The following is a description of a gene set: Mouse Gene Set: MONNIER_POSTRADIATION_TUMOR_ESCAPE_UP from publication Monnier Y, Farmer P, Bieler G, Imaizumi N, Sengstag T, Alghisi GC, Stehle JC, Ciarloni L, Andrejevic-Blant S, Moeckli R, Mirimanoff RO, Goodman SL, Delorenzi M, Rüegg C (PMID 18794119) Radiotherapy is widely used to treat human cancer. Patients locally recurring after radiotherapy, however, have increased risk of metastatic progression and poor prognosis. The clinical management of postradiation recurrences remains an unresolved issue. Tumors growing in preirradiated tissues have an increased fraction of hypoxic cells and are more metastatic, a condition known as tumor bed effect. The transcription factor hypoxia inducible factor (HIF)-1 promotes invasion and metastasis of hypoxic tumors, but its role in the tumor bed effect has not been reported. Here, we show that tumor cells derived from SCCVII and HCT116 tumors growing in a preirradiated bed, or selected in vitro through repeated cycles of severe hypoxia, retain invasive and metastatic capacities when returned to normoxia. HIF activity, although facilitating metastatic spreading of tumors growing in a preirradiated bed, is not essential. Through gene expression profiling and gain- and loss-of-function experiments, we identified the matricellular protein CYR61 and alphaVbeta5 integrin as proteins cooperating to mediate these effects. The anti-alphaV integrin monoclonal antibody 17E6 and the small molecular alphaVbeta3/alphaVbeta5 integrin inhibitor EMD121974 suppressed invasion and metastasis induced by CYR61 and attenuated metastasis of tumors growing within a preirradiated field. These results represent a conceptual advance to the understanding of the tumor bed effect and identify CYR61 and alphaVbeta5 integrin as proteins that cooperate to mediate metastasis. They also identify alphaV integrin inhibition as a potential therapeutic approach for preventing metastasis in patients at risk for postradiation recurrences. studied in species Mus musculus The postradiation tumor escape signature: genes up-regulated in tumors from irradiated stroma vs those from non-irradiated stroma., and this is the list of marker genes: Elac2, Cfap45, Urb2, Grwd1, Oasl1, Zkscan3, Slc6a8, Srek1, Atp1a1, Pmm2, Lhfpl6, Abce1, Camk2d, Ppif, Pdpn, Kat2a, Akap1, Ahrr, Rassf1, Kansl2, Sntb2, Hspa4l, Otud4, 1110038B12Rik, Rrp8, Mlec, Ccnb1ip1, Atp2b1, Ddx6, Tirap, Zfp91, Ube2l3, Tspan14, Hspa1b, Rab35, Naa15, Chd4, Vat1, Dusp9, Ankrd33b, 6030458C11Rik, Cdh5, Srm, Ccar1, G3bp2, 2610005L07Rik, Map3k7, Gng12, Ppat, Rbm25, Cdk8, Msi2, Adipor1, Il11, Slc10a3, Nqo1, Atp1b1, Oxr1, Fam167b, Elp1, Blnk, Prkar2b, Dnmt3l, Rlim, Ramp3, Rrp7a, Tex261, Grem1, Aebp1, Lypd3 (NCBI Gene Id 72434), Xpo4, Sh3pxd2a, Zfp335 (NCBI Gene Id 69801), Nmt2, Mrpl15, Ddx46, Spire2, Deptor (NCBI Gene Id 97998), Ergic1, Bnc2, Slc11a2, Neat1, Bace1, Ccnt1 (NCBI Gene Id 72830), Fkbp4, Luc7l3, Usp20, Kif21a, Itprip, Prcp, Kpnb1, Csnk1g1, Tada2b, Tfdp2, Eaf1, Zfyve27, Tsr1, Tbrg4, Scap, Slc25a10, Nrp1, Dhx33, Rbm14, Ass1, Smad1, Ptpn11, Ttpal, Pgs1, Dus3l, Dap, Wipf2, Sec22c, Zdhhc3, Tardbp, Tango6, Ago2, Hgh1, Rack1, Naa16, Mmp2, Zfp866, Crebbp, Txlna, Zc3h18, Utp4, Mtf2, Lrig1, Rad23b, Ablim1, Ubiad1, Mtr, Rrp12, Crhr1, Xpo6, Ap1ar, Mafg, Smim36, Slc39a6, Rbm27 (RNA binding motif protein 27), Mfsd10, Sgip1, Ak1, Zmpste24, Nop9, Txnrd1, Ampd2, Gm42047, Xpo5, Mmd, Slc19a1, Odc1, Rnd1, Pik3r1, Gpc1, Lrrc14, Smurf1, Prpf4, Fastkd3, Dync1li2, Ints6, Pdzrn3, Ssx2ip, 1700041M19Rik, Eif4g1, Trim2, Fam149a, Pabpn1, Gpd1l, Faap24 (Fanconi anemia core complex associated protein 24), Gls, Prr3, G6pdx, Ptgs1, Bbx, Slc48a1, Naa25, Pdap1, Pa2g4 (proliferation-associated 2G4), Slc25a32, Traf4, Ddx54, Ppm1l, Pdpr, Syncrip, Akr1b1 (aldo-keto reductase family 1 member B), Aqp5, Lrrc59, Cdk2ap1, Senp2, Mtmr9, Crebzf, Nop56, Bap1, Pigl, Kctd17, Sec23ip, Fdx1, Selenow, Rnf183, Zmynd19, Socs6, Khdc4, Asrgl1 (NCBI Gene Id 66514), Fam53c (family with sequence similarity 53, member C), Clec1a, Faim2, Pnpla6, Senp3, Fam98a, Gm17491, Pwp2, Pde12, Strap, Smyd5, Shroom4, Cenpa, Cxcl5, Ttc39c, Bop1, Abcc1, Uaca (uveal autoantigen with coiled-coil domains and ankyrin repeats), Gclm, Map2k3, Sdc1, Proser1, Clba1, Cntn2, Asph (aspartate-beta-hydroxylase), Gatad2a, Tsc22d1, Supv3l1, Tns3, Ddx51, Pabpc4, Rab5c, Mcc, Vcan, Fam83g, Nipbl (NIPBL cohesin loading factor), Slmap, 5033421B08Rik, Kcnk5, Kcnq1ot1, Trmt61a, Nnmt, Ddx3x, Ash2l, Pdcd11, Slc35a4, Scai, Espl1, Ppp1r10 (NCBI Gene Id 66450), Slc35b4, Airim, Iapp, Kcnu1, Fam32a, 2700038G22Rik, Samd4, Ccdc93, Dhx9, Il1rl1, Pcx, Trmt6, Gldc, Anxa11, Prpf3, Ipo4, Gtf3c6, Mrps15, Ankrd13a, Usp19, Rapgef6, Zmat3, Fastkd1, Nhlrc2, Eif3b, Enpp2 (NCBI Gene Id 223584), Smarcc1, Alg10b, Pgd, Sdad1, Traf2, Scin, Slc66a2, Rcc1, Taok1, Aph1a, Sltm, Hmga1, Prmt6, Rcc1l, Wdr46, Nolc1, Tspan5, Aven, Slco3a1, Letm1, Smarca4, Map4k4, Nfkbie, Bcat1, Tpm1, Marchf5, Ilrun, Yap1, Pcbp2, Ino80e, Prkca, Vps33a (NCBI Gene Id 77573), Zfp267, Rab8b, Actr1b, Mir1949, Slc7a6, Gemin5, Mettl1, Slc12a2, Mtdh, Slc22a23, Ftsj3, Fosl1, Gtf2h1, Ints13, Gspt1, Nol8, Nploc4, Cisd3, Ppm1f, Slit2, Sumo3, LTO1, Poldip2, Il18r1, Sptbn1, Aen, Dynll2, Prl2c2, Sfpq, Ncbp1, Mybbp1a, Ets1, Lonp1, Myo10, Btaf1, Xdh, Mthfd1, Slc14a1, Ccl5 (NCBI Gene Id 20304), Bms1, Pcyt1a, Zfp560, Mybl2, Marcksl1, Letmd1, Gmps, Ppp1r12b, Tnfaip2, Eif4ebp2, Thoc3, Hspa4, Rwdd4a, Hipk1, Snhg3, Eeig1, Pop1 (NCBI Gene Id 67724), Ereg, Gosr2, Rbm19, Alkbh1, Gclc, Nemf, Rsrc2, Myd88, Rhoj, Ints2, Atp2a2, Slc15a3, Gon4l, Hnrnpk, Abitram (actin binding transcription modulator), Mrgprf, Otud7b, Ncs1, Brd2, Smg5, Mcmbp, Cdk6, Srprb, Polr1a, Rapgef1, Kmt5a, Man1a, Slc25a44, Lbhd1, Mlst8, Ltbp1, Mei1, Ptdss1, Pnn, Zfp322a, Rundc1, Zfp106, Epb41l1, Ubxn8, Noa1, Tfrc, Txn2, Etf1, Prrx1, Gsr, Etv6, Arglu1, Cgnl1, Rpap1